Given this list of marker genes RCC1L, SOCS1, PTEN, PIAS2, PHTF1, GARNL3, MSI2, here is a description of the gene set: species: Homo sapiens from publication Palomero T, Sulis ML, Cortina M, Real PJ, Barnes K, Ciofani M, Caparros E, Buteau J, Brown K, Perkins SL, Bhagat G, Agarwal AM, Basso G, Castillo M, Nagase S, Cordon-Cardo C, Parsons R, Zúñiga-Pflücker JC, Dominguez M, Ferrando AA (PMID 17873882) Up-regulated genes associated with sensitivity and resistance to gamma-secretase (GSI) in T-cell acute lymphoblastic leukemia (T-ALL) cell lines. Human Gene Set: PALOMERO_GSI_SENSITIVITY_UP Gain-of-function mutations in NOTCH1 are common in T-cell lymphoblastic leukemias and lymphomas (T-ALL), making this receptor a promising target for drugs such as gamma-secretase inhibitors, which block a proteolytic cleavage required for NOTCH1 activation. However, the enthusiasm for these therapies has been tempered by tumor resistance and the paucity of information on the oncogenic programs regulated by oncogenic NOTCH1. Here we show that NOTCH1 regulates the expression of PTEN (encoding phosphatase and tensin homolog) and the activity of the phosphoinositol-3 kinase (PI3K)-AKT signaling pathway in normal and leukemic T cells. Notch signaling and the PI3K-AKT pathway synergize in vivo in a Drosophila melanogaster model of Notch-induced tumorigenesis, and mutational loss of PTEN is associated with human T-ALL resistance to pharmacological inhibition of NOTCH1. Overall, these findings identify transcriptional control of PTEN and regulation of the PI3K-AKT pathway as key elements of the leukemogenic program activated by NOTCH1 and provide the basis for the design of new therapeutic strategies for T-ALL.